Given this list of marker genes Eya2, Zfp13, Stpg1, Mpv17l, Bloc1s2, Atf2, Slc25a4, Ppif, Bcl2l11, Acaa2, Bax, Atp5if1, Slc25a31, Slc9a1 (NCBI Gene Id 20544), Bak1, Chchd10, Slc25a5, Bcl2l1, Hip1r (NCBI Gene Id 29816), Siva1, Bid, Ier3, Spg7, Mul1, Trp53, Bok, Bnip3, Gclc, Rhot2, Gsk3a (glycogen synthase kinase 3 alpha), Fzd9 (frizzled class receptor 9), Rhot1, Vdac2, Tmem14a, Tmem102, Gsk3b, Bnip3l, Fxn, Slc35f6, here is a description of the gene set: Mouse Gene Set: GOBP_POSITIVE_REGULATION_OF_MITOCHONDRIAL_MEMBRANE_PERMEABILITY Any process that increases the frequency, rate or extent of the passage or uptake of molecules by the mitochondrial membrane. studied in species Mus musculus